Given this list of marker genes MAD2L1BP, PLSCR1, NCAPD2, MAPK15, DLGAP5, UBE2C, NCAPH, ANAPC5, NSMCE2, RB1, ESPL1, NCAPG, BIRC5, NUMA1, INCENP, SMC4, PRAP1, CDCA8, ANAPC7, ANAPC11, CDC20, NCAPD3, NCAPG2, MAD1L1 (NCBI Gene Id 8379), SMC2, NCAPH2, CUL3, AURKB, SKA3, CDC23, SKA1, CDC16, here is a description of the gene set: studied in species Homo sapiens Human Gene Set: GOBP_POSITIVE_REGULATION_OF_CHROMOSOME_SEPARATION Any process that activates or increases the frequency, rate or extent of chromosome separation.